The following is a description of a gene set: studied in species Mus musculus Mouse Gene Set: GOBP_PLATELET_DERIVED_GROWTH_FACTOR_RECEPTOR_BETA_SIGNALING_PATHWAY The series of molecular signals initiated by the binding of a ligand to a beta-type platelet-derived growth factor receptor (PDGFbeta) on the surface of a signal-receiving cell, and ending with the regulation of a downstream cellular process, e.g. transcription., and this is the list of marker genes: Epha8, Mertk, Ephb2, Ephb1, Ptpn1, Epha2, Ephb4, Flt1, Flt4, Kdr, Ret, Fgfr2, Musk, Mst1r, Epha1, Flt3, Egfr, Epha7, Fgfr3, Ddr1, Ntrk1, Ror2, Pdgfb, Met, Epha6, Erbb4, Csf1r, Alk, Tie1, Pdgfrb (NCBI Gene Id 18596), Myocd, Hip1, Ephb3, Fgfr4, Hip1r, Src, Pdgfa, Axl, Clasp2, Kit, Ros1, Epha5, Tek, Ptpn2, Erbb2, Ntrk2, Epha3, Tyro3, Lrp1 (NCBI Gene Id 16971), Insrr, Ddr2, Ntrk3, Pdgfra, Ltk, Fgfr1, Abl1, Igf1r, Lox, Epha10, Epha4 (Eph receptor A4), Insr (NCBI Gene Id 319666)